Given this list of marker genes STOX1, RNF207, MIR21, SHH, MAGED1, FKBPL, FGF1, WNT5A, SIX1, CAV3, HGF, BMP4, GDNF, MDK, SULF1, MMRN2, TNF, ESR1, SMO, SFRP1, GATA3 (GATA binding protein 3), TACSTD2, NTN4, PAX8, EGF, FOXP1 (forkhead box P1), PDGFA, ABL1, FGF7, WNT2, ADAMTS12, PHB2, BMP7, CTNNB1, LHX1 (LIM homeobox 1), SOX8, HOXB7, AR, LBX2, SIRT6, SIX2, ETV5, PIK3CD, LCN2, SIX4, GREM1, TBX2, SOX9, SNAI2, WNT2B, TGFB1, PAX2, ITGAX (integrin subunit alpha X), AGTR2, FGFR1 (fibroblast growth factor receptor 1), WNT4 (Wnt family member 4, NCBI Gene Id 54361), GJA1, BTBD7, CXCL10, WNT5B (NCBI Gene Id 84728), AGT, NOG, HOXD13, FGF2, CTNND1, LGR4, FGF10, LIF, VEGFA (vascular endothelial growth factor A), here is a description of the gene set: studied in species Homo sapiens Any process that modulates the frequency, rate or extent of morphogenesis of an epithelium. Human Gene Set: GOBP_REGULATION_OF_MORPHOGENESIS_OF_AN_EPITHELIUM